The following is a description of a gene set: Human Gene Set: GSE20727_H2O2_VS_ROS_INHIBITOR_TREATED_DC_DN Identification of ROS induced genes on dendritic cells Dendritic cells were incubated for 15 min with or without a ROS inhibitor (DPI), washed extensively and incubated for 30 min with a chemical allergen (DNFB), hydrogen peroxide, and vehicle alone in HBSS containing DPI or vehicle. After washed extensively, the samples were post-incubated for 5.5 h with DNFB, hydrogen peroxide, or vehicle in complete culture medium containing DPI or vehicle. species: Homo sapiens Genes down-regulated in dendritic cells: hydrogen peroxide versus diphenyleneiodonium (DPI). from publication Miyazawa M, Takashima A (PMID 22974541), and this is the list of marker genes: RASGRP1, RPS4X, GGPS1, INSR, GPR146, IQSEC1, MARVELD1, CCDC126, NOCT, DBP, TXK, NR1D2, WASL, AFG2B, CCDC28A, PACC1, NIPSNAP2, CDADC1, AKAP9 (A-kinase anchoring protein 9), TSC1, MRPL23, ZNF467, SELL, CCDC91, ZBTB39, PDIA2, P2RX4, CALCRL, EGR3, RUNDC3B, ID3, CD7, LINC00511, ALG1, SLFN13, LDHB, RAD52, GATA1, TBC1D15 (NCBI Gene Id 64786), KLK8, SSH2, ZC3H8, PCMTD2, ZDHHC14, TMEM87B, SETX, ASIC3, RTCB, ST3GAL1, PGC, CDKN1B, ZNF606, MTMR2, ZNF655, LETM2, GP1BA, FLCN, MAP2K7, RPL17, NRIP3, ZNF420, NIPBL, TET1, SLFN5, JMJD1C, CEBPZ, TMCC1, BRAF, RASA2, LCOR, SEMA4F, SENP6, ZBTB40, TCF20 (transcription factor 20), UBE2D2, RPS19, JMJD8, UTRN, ABHD15, NPM1, PFKFB2, THADA, PPARGC1B, BBS2 (Bardet-Biedl syndrome 2), GKN1, ZBTB11-AS1, RPP40, PPP1R3F, PPM1L, FAM8A1, SH3BP5 (SH3 domain binding protein 5), ZBTB20, TMEM63A (NCBI Gene Id 9725), TLR1, KIAA0930, TRPC5, CARD6, TLK2, FOXO3, RASGRF2, HSD17B11, ATN1, ATXN7L1, NR3C1, TMEM185A (transmembrane protein 185A), ZDHHC17, S1PR1, BTG1, KLHL6, HVCN1, TRIM56, TCF7, FNDC10, FRMD4A, CCDC66, SNN, ITM2A, RPLP2, HEATR1, SNHG10, IER5, USP12, BFAR, ATF7IP, KMT2C, TSPAN13, ZNF354C, TSR2, RPL37, RC3H1, RAMP1, FILIP1L, ACSS1, ZBTB26, TESC, RPL35, SELENOP (selenoprotein P), ABCG1, IKBKE, BTG2, IGSF9B, LYPD6B (NCBI Gene Id 130576), DDIT3, BZW2, CFLAR, PPP1R3B, EVL, ATP8A1, EPHX1, SLC25A27, TGFBR2, ARID4B, YAE1, CLK1, DAPL1 (death associated protein like 1), XPC, CNR2, FOXO1, RPL5, PRMT3, CAMKMT, BCOR, LENG1, REEP1, GPRASP1, LTA, MYCBP2 (MYC binding protein 2), ABI3, SH2B3, SRRM2, RELCH (RAB11 binding and LisH domain, coiled-coil and HEAT repeat containing), TCP11L2, GANC, ARID1B, AQP6, RMDN1, KBTBD11, ACADM, CLCN6, PRR22 (proline rich 22), SATB1 (SATB homeobox 1), RABGAP1, EEF1G, ERBIN, ZFP36L1, PHF23, ARHGAP35, CAMSAP2, AMER1, AFF3, SKIL (NCBI Gene Id 6498), ZYG11B, OGA, RPL36, EIF4B, ZMYM5, ARHGAP29, AMACR, SKI